Given this list of marker genes RBBP8, EED, APAF1, TFDP2, CBX5, UXT, CDC7, CHEK1, PCGF6, BMI1, RING1, E2F1, RBBP7, EZH2, E2F6, BRCA1, SUZ12, RBBP4, CBX3, MGA, PHC1, RNF2, EHMT2, RRM2, L3MBTL2, PCGF2, EHMT1, RYBP, TFDP1, PHC3, MAX, RAD51, EPC1, YAF2, here is a description of the gene set: Transcriptional Regulation by E2F6 Human Gene Set: REACTOME_TRANSCRIPTIONAL_REGULATION_BY_E2F6 species: Homo sapiens